Given this list of marker genes Zbtb16, Cntrl, Etv5, Stra8, Ing2, Tdrd12, here is a description of the gene set: The self-renewing division of a germline stem cell to produce a daughter stem cell and a daughter germ cell, which will divide to form the gametes. Mouse Gene Set: GOBP_GERM_LINE_STEM_CELL_DIVISION species: Mus musculus